The following is a description of a gene set: Binding to a polymer of the small ubiquitin-like protein SUMO. Human Gene Set: GOMF_SUMO_POLYMER_BINDING studied in species Homo sapiens, and this is the list of marker genes: SOBP, RNF4, CASP8AP2, RNF111, SIMC1, GCNA